The following is a description of a gene set: Reactome Pathway: Regulation of necroptotic cell death part of: RIPK1-mediated regulated necrosis electronically inferred by orthology from the curated human pathway This event has been computationally inferred from an event that has been demonstrated in another species.<p>The inference is based on the homology mapping from PANTHER. Briefly, reactions for which all involved PhysicalEntities (in input, output and catalyst) have a mapped orthologue/paralogue (for complexes at least 75% of components must have a mapping) are inferred to the other species. studied in species Mus musculus, and this is the list of marker genes: Ubb, Flot2, Tradd (TNFRSF1A-associated via death domain), Fas, Flot1, Mlkl, Rps27a, Cdc37, Sdcbp, Casp8, Birc3, Prkn, Fasl, Fadd